The following is a description of a gene set: from publication Xie S, Zhou N, Su N, Xiao Z, Wei S, Yang Y, Liu J, Li W, Zhang B (PMID 38577019) Mouse Gene Set: XIE_TRASTUZUMAB_CARDIOTOXICITY_MMU_MIR_708_5P_GENES Abstract: Trastuzumab-induced cardiotoxicity (TIC) is a common and serious disease with abnormal cardiac function. Accumulating evidence has indicated certain non-coding RNAs (ncRNAs), functioning as competing endogenous RNAs (ceRNAs), impacting the progression of cardiovascular diseases. Nonetheless, the specific involvement of ncRNA-mediated ceRNA regulatory mechanisms in TIC remains elusive. The present research aims to comprehensively investigate changes in the expressions of all ncRNA using whole-transcriptome RNA sequencing. The sequencing analysis unveiled significant dysregulation, identifying a total of 43 circular RNAs (circRNAs), 270 long noncoding RNAs (lncRNAs), 12 microRNAs (miRNAs), and 4131 mRNAs in trastuzumab-treated mouse hearts. Subsequently, circRNA-based ceRNA networks consisting of 82 nodes and 91 edges, as well as lncRNA-based ceRNA networks comprising 111 nodes and 112 edges, were constructed. Using the CytoNCA plugin, pivotal genes - miR-31-5p and miR-644-5p - were identified within these networks, exhibiting potential relevance in TIC treatment. Additionally, KEGG and GO analyses were conducted to explore the functional pathways associated with the genes within the ceRNA networks. The outcomes of the predicted ceRNAs and bioinformatics analyses elucidated the plausible involvement of ncRNAs in TIC pathogenesis. This insight contributes to a better understanding of underlying mechanisms and aids in identifying promising targets for effective prevention and treatment strategies. studied in species Mus musculus, and this is the list of marker genes: Mroh1, Zdhhc24, Trp53bp1, Hebp2, Cdk19, Cyld, Errfi1, Fam168b, Frmd4a, Golga1, Atcay, Dand5, Ak4, Sp2, Fblim1, Atg9a, P3h1, Frmpd2, Ldb3, Syngr2, Npy4r, Fbxo41, Amph, Armcx6, Zbtb21, Clec16a, Pcyt1a, Tmcc3, Pfkfb3, Zbtb8b, Matcap1, Supt7l, Fndc7, Hdhd2, Zbtb43, Map3k13, Tead1, Adgrl3, Rab22a, Nbr1, Ddx11, Specc1, Ripor2, Bend3, Clmn, Snrk, Adipor2